Given this list of marker genes DYNLT2, MARCKS, SGPP2, STAT5A, SLC1A2, BASP1 (NCBI Gene Id 10409), B4GALT5 (NCBI Gene Id 9334), KLF5, MPP3, TGIF2LX, LIN28B, ABCA1, ANP32D, ZCWPW1, CATSPER2 (cation channel sperm associated 2), ZC3H12C, ADAM22, FRY, ATP2B1, CALY, TNP1, ADAM17, DDR2, TOB2 (transducer of ERBB2, 2), ESCO2, LCOR, ANKLE2, G0S2, NOTCH4, ARL4D, MAK, XIRP1, CYP2C9, IQCH, FUBP3, SYT9, TDRP, VEGFA, FLJ13224, OGFRP1, CXCL10, PNLIPRP1, IL1B, DMXL2, AFF3, SRC, NLRP14, IL18, RAB6B, NANOS2, GABRA1, IL10, DENND5A, CCDC65, JAG1, GNAS, SVIL, SNTG1, JRK, GH2, SELENBP1, TRAF1, PURB, EDN1, CLEC4E, CTF1, RAPGEF2, IL1A, CCL15, SLC2A11, RAG2, BRINP1, AGBL1, MIIP, ZEB2, SOD2, IL12B, CA8, SEMA6C, ATXN1, TTC9, CANX, CFTR, KIR2DL1, SQSTM1, PSD3, SLC28A1, TLR7, GPC1, FCRL5, TRIP10, RND3, DUSP2, PPP3CC, PCNX2, ELOVL7, SYCE1, CFAP69, DPYSL3, PLK3, CEP350, DTX2 (NCBI Gene Id 57652), SLC22A23, C5orf47, PNLIP, TNFAIP3, PNRC1, RAB3GAP2, NME7, PXDC1, ZNF334, SLCO3A1, LITAF, MAGEA5P, GPR84, TLR2, TNF, SHD, GARIN1A, CDON, ACSL1, AKAP12, BPIFA3, RGS16, CFLAR, NFKBIA, HSPA1B, KLHL3, CFAP65, CREB5, STBD1, MIR23AHG, ACOT6, LSS, CXCL1, TBC1D9, SRGAP1, DCAF8, LINC00112, ZC3H12A, WDR87, COBL, KXD1, TADA3, LINC02593, KDM6B, SKAP1-AS2, SERPINB8, ALCAM, SERPINE1, SMAD4, TNIP2, RPS2P45, CNKSR3, GFER, PDGFB, BCL11A, DRAM1, SPON1, EHD1, HES4, ATP1B1, WTAP, EOLA1-DT, GEMIN7, TP53INP2, PDE2A, IL23A, ZG16, DUSP1, WNT5A, ST7-AS1, FGFR1OP2, LIF, TMCO2, ITGB8, PLPP3, TCF7L2, C22orf15, CCL23, COL26A1, PKM, SLC6A15, IL1R1, SEMA6A, SLC2A6, UPK2, PLAGL2, PXDN, LDLR, SPP2, CDH15, SDC4, ZNF131, NR4A3, ADM, VAPB, HOXB1, REM2, KLHL4, BTBD19 (NCBI Gene Id 149478), GSK3B, PCDH9, KRT36, ELOA2, MTF1, KRTAP3-3, MMP8, LINC00851 (long intergenic non-protein coding RNA 851), KANK1, DYNC1I1, NCK2, TPM4, FERMT2, PKP1, NIPAL4, RSPO1, IRF8, CIMAP1B, GIPR, CCL4, ZNF876P, CD44, SYDE1, MN1, SLC2A13, TLNRD1, UBE2FP1, BTBD9, EPB41, KLC2, ACOD1, KCNAB1, CD83, TNFRSF9, KLHL28, NRL, MIER1, OSR2, AGO2, CD55, F3, EGR4, ZFYVE16, CLCF1, NKX3-1, KLF6, SPSB1, SFPQ, CCN5, STARD8, SLC5A1 (NCBI Gene Id 6523), FOXP2, ARHGAP31, MIR22HG, MAP1B, USF3, NINJ1, RCAN1, SLC26A9, TMEM67, EREG, ACVR2A, PIM3, PRMT5-AS1, SPAM1, MACF1, OTUD7B (NCBI Gene Id 56957), GPC3 (glypican 3), HDAC4, PPP1R14A, DNHD1, PALLD, PDP1, RASGEF1B (NCBI Gene Id 153020), IQCG, NEDD4L, DUSP5, CD24P4, DCAKD, C11orf96, PTX3, IL6, ADGRL3, LINC01138, TNFAIP2, BRICD5, CD80, DYRK3, NFAT5, FTX, SHANK1, ENSG00000274565, IYD, AFF4, LEF1-AS1, SERPINB2, HGF, TSLP, ICOSLG, PLA2G5, ATP2B2, TPD52, AKAP1, DDX42, LINC02762, TNFSF9, AKNAD1, LMO3, NECAP2, ANKHD1, WNK4 (NCBI Gene Id 84361), ID4, NDRG1, KDM7A-DT, DYNC1H1, CPEB4, RIPK2, IER3, ENSG00000237870, KICS2, FSCN1, COL4A1, RELB, ZNF778-DT, BFSP1, LINC00221, BMS1P17, DOT1L, COL11A1, CSF3, MSC, MYL2, MAFF, SEPTIN4, FAAP20 (FA core complex associated protein 20), SMTN, TRIM36, CCRL2, ATP2B1-AS1, ARMC5, PWWP3B, ICAM1, SLC28A2, MAP2K3, RNF213, NAMPT, HEY1, EYA4, HAPLN1, MBNL1, PAX3, FUT4, MRI1 (methylthioribose-1-phosphate isomerase 1), GRIN2A, LIMK2, B4GALT1, ST3GAL1, OSM, OAF, GRAMD1A, MFSD2A, KLHL41, LINC00630, DMRTA1, CA13, LAMA3, RAPH1, SLC39A14, PTPN11, ZBTB43, CYB5D1, NFKB2, CXCL3, IRAK2, TMC6 (NCBI Gene Id 117165), NCAN, TPRA1, EDNRA, TMPRSS6, HPS4, CADPS, PRKCD, ICA1L, PTPN1, DEFB108B, KLHL14, MIR3142HG, S1PR3, BAMBI, MAGEA10, KIF1B, NEFL, NUDT16-DT (NCBI Gene Id 339874), MYOG, NBN, PTGS2, ADORA2A-AS1, FNDC3B, NDP, NCF4-AS1, OR7C1, EIF5, FFAR2, IGHV5-78, TNS1, LINC03025, PALM2AKAP2, TFAP2B, RNF144B, TNFSF15, GPM6A, SGMS2, BTG2, RARRES1, ABL2, PPP1R15A, ICAM4, PLAUR, ABCC11, HPN, EVI5L, TNIP1, NFKBID, HECTD2, ITPRIP, KCNE4, KRT19, QRICH2, DCAF12L1, SNN, DNAJB5, NFKB1, YRDC (NCBI Gene Id 79693), IL17RE, STON2, DMRTC2, CXCL2, HSPA1A, LIFR, RCN3, CCL20, CYP7A1, P2RX7, FOSL1, HOXA6, PGM5, REL, MAB21L1, RAP2C, CGAS, SOD3, NCOR2, here is a description of the gene set: from publication Zhou Q, Amar S (PMID 18025224) Human Gene Set: ZHOU_INFLAMMATORY_RESPONSE_LIVE_UP Genes up-regulated in macrophage by live P.gingivalis. Porphyromonas gingivalis (P. gingivalis) can trigger an inflammatory condition leading to the destruction of periodontal tissues. However P. gingivalis LPS and its fimbriae (FimA) play different roles compared with the live bacteria in the context of intracellular molecule induction and cytokine secretion. To elucidate whether this difference results from different signaling pathways in host immune response to P. gingivalis, its LPS, or its FimA, we examined gene expression profile of human macrophages exposed to P. gingivalis, its LPS, or its FimA. A comparison of gene expression resulted in the identification of three distinct groups of expressed genes. Furthermore, computer-assisted promoter analysis of a subset of each group of differentially regulated genes revealed four putative transcriptional regulation models that associate with transcription factors NFkappaB, IRF7, and KLF4. Using gene knockout mice and siRNA to silence mouse genes, we showed that both TLR2 and TLR7 are essential for the induction of NFkappaB-containing genes and NFkappaB-IFN-sensitive response element (ISRE) cocontaining genes by either P. gingivalis or its purified components. The gene induction via either TLR2 or TLR7 is dependent on both MyD88 and p38 MAPK. However, the unique induction of IFN-beta by P. gingivalis LPS requires TLR7 and IFNalphabetaR cosignaling, and the induction of ISRE-containing gene is dependent on the activation of IFN-beta autocrine loop. Taken together, these data demonstrate that P. gingivalis and its components induce NFkappaB-containing genes through either TLR2- or TLR7-MyD88-p38 MAPK pathway, while P. gingivalis LPS uniquely induces ISRE-containing genes, which requires IFNalphabetaR signaling involving IRF7, KLF4, and pY701 STAT1. species: Homo sapiens